Given this list of marker genes AAGAB, AKT1, UROD, NEUROD1, REST, DCC, TNFSF15, ASCC1, FAH, FGFR2, TNFSF12, KLF11, ABCB4, RNF43, RPGRIP1L, GATA1, TP53, RPS24, DZIP1L, ARID1A, MGMT, CHEK2, MSH6, SKIC2, SEMA4D, GPC4, FH, APC, PTPRJ, STAT6, CD19, KIT, GDF2 (growth differentiation factor 2), ASL, NAB2, NFKB1, RPS19, INPP5E, KLLN, CD81, SDHC, AIP, COL4A5, PHKA2, IGF2, C1S, NFKB2, PIK3CA, RABL3, TNPO3, MSH2, PALLD, SEMA4A, RAD51, TNFRSF13C, BRAF, SMPD1, CPOX, H19, SMARCD1, KCNQ1OT1, HMBS, NF1, MMEL1, NBN, RAD51C, CR2, SKIC3, HFE, RPL15, YY1, MC1R, SMARCE1, SOX11, MYH11, PDGFRA, SRC, PPOX, CDK4, SDHD, IL1RN, IL12A, PIEZO2, DLK1, BLM, RPS15A, CTHRC1, ROS1, RPL11, FAS, TRIM28, KEAP1, ARID1B, SETBP1, CDKN2C, RPS7, CEP57, FASLG, SPIB, RPL35A, RTL1, GIMAP5, ZFTA (zinc finger translocation associated), PTPN3, RPS20, ABCB11, CTNNB1, FGFR3, IRF2BP2, TULP3, CDKN2A, CCND1, CDKN1B, SMARCB1, PDX1, MBD4, JAG1, WT1, POLE, BRCA2, HEATR3, PMS1, PSENEN, PLA2G2A, POFUT1, TLR2, PKHD1, RPL31, RNF6, HEPACAM, PMS2 (PMS1 homolog 2, mismatch repair system component), RHBDF2, TMEM67 (transmembrane protein 67), RPS28, MCC, KRAS, RPS17, COL14A1, BUB3, COL4A6, ADA2, BUB1B, RPL27, CREBBP, DICER1, PSAP, FLCN, ARID2, KRT5, RAD50, GCGR, ACD, RAD21, PDGFRL (platelet derived growth factor receptor like), MRE11 (NCBI Gene Id 4361), MSR1, ICOS, CDH1, SMAD4, DIS3L2, CASP8, BMP6, STK11, SMARCA4, MSH3, PALB2, WWOX, ENG, MEN1, INS, ATP7B, VHL, POU6F2, GPR101 (G protein-coupled receptor 101), RPL8, CASP10, ATP2A2, PAX4, GCK, RPS26, ARSA, CDKN2B, HNF1A, RAD54B, SPRED1, PYGL, F5, HBB, SOX4, PTCH1, PDE11A, RAD51D, BARD1, POU2AF1, GPR35, LZTS1, CC2D2A, G6PC1, GNAS, POGLUT1, MUTYH, USF3, IRF5, MST1, SMARCC2, KCNJ11, BUB1, SLC2A2, MLH1, RPS27, BAP1, MDM2, ABCC8, IGF2R (insulin like growth factor 2 receptor), BLK, BMP2, MAD1L1, PHKG2, TRIP13, APPL1, AURKA, RPS29, AXIN1, HABP2, KCNQ1, JAK2, GREM1, ZFX, SMAD7, RPL35, SEC23B, IL12RB1, PHKB (phosphorylase kinase regulatory subunit beta), SLC37A4, STAT1, GPC3, BAX, DOCK8 (dedicator of cytokinesis 8, NCBI Gene Id 81704), RPS10, MTOR, TERT, CDKN1A, TGFBR2, SPRTN, BMPR1A, RPL9, CEL, MPV17, NRAS, SERPINA1, SLC25A13, DLEC1, MS4A1, BTK, TREX1, IRF1, EP300, BRCA1, MINPP1, CDKN1C (NCBI Gene Id 702), SDHB, MEG3, TNFRSF13B, AXIN2, ACVRL1, EPCAM, KLF6, FOXE1, ATRX, POT1, TCF4, ATM, BCL10, PTEN, SDHA, PRKAR1A, RPL26, DLC1, DPF2, DKC1, RPL18, ERBB2, NTHL1, TSR2, LMNA, POLD1, TERF2IP, PTPN12, HNF4A, MITF, TJP2 (NCBI Gene Id 9414), MLH3 (mutL homolog 3), WRN, AHCY, MET (NCBI Gene Id 4233), RPL5, IL1B, BRIP1, here is a description of the gene set: Neoplasm of the gastrointestinal tract Human Gene Set: HP_NEOPLASM_OF_THE_GASTROINTESTINAL_TRACT studied in species Homo sapiens A tumor (abnormal growth of tissue) of the gastrointestinal tract.